The following is a description of a gene set: species: Mus musculus Binding to ADP, adenosine 5'-diphosphate. Mouse Gene Set: GOMF_ADP_BINDING, and this is the list of marker genes: Msh2, Grpel1, Mat1a, Nod2, Lonp1, Myo3a, Bag2, Apaf1, Hspa4l, Chordc1, Ppp5c, Ruvbl1, Myh9, Hspa4, Grpel2, Myo9b, Ruvbl2, Myh10, Atp1a1, Hyou1, Atp5f1a, Pfn1, Glud1, Hsph1, Bag1, Tap2, Sil1, P2ry1, Hspa8, Hspbp1, Atp5f1b, Nlrp3, Abcd1, H1f4, Myo18a, Prkag2, Prps2, Tap1, Cyb5r3, Mief1, Gck, Abcg1, Myo7a, Vcp, Pkm, Pgk2, Coq8a, Ern1, Prps1, Bag3, Gclc, Msh6, Prkag1, Bag5, Pgk1, Abcc8, Bag4